The following is a description of a gene set: Human Gene Set: chr14q12 species: Homo sapiens, and this is the list of marker genes: REC8, SCFD1 (sec1 family domain containing 1), NFATC4, LINC02282 (long intergenic non-protein coding RNA 2282), RIPK3, HMGN2P6, TM9SF1 (NCBI Gene Id 10548), LINC02300, NRL, COCH, ZFAND2AP2, FOXG1, RN7SL660P, RNU11-5P, PSME2, RNF31, ADCY4, RPL21P5, TINF2, MIR4307HG, MIR4307, IPO4, CHMP4A, ARHGAP5-AS1, DCAF11, GZMB, CYB5AP5, AKAP6, NOVA1-DT, LINC02306, ARHGAP5, LTB4R2, LINC02294, CBLN3, RNU6-541P, GZMH, FOXG1-AS1, AP4S1, LINC02286, LINC02326, LINC00645, UBE2CP1, NOP9 (NOP9 nucleolar protein), LINC01551, SYF2P1, RPL26P3, G2E3-AS1, RABGGTA, BNIP3P1, LINC02313, BTF3P2, KHNYN, MIR7703, RNU6-864P (NCBI Gene Id 106481776), OR7K1P, KIAA1143P1, LTB4R, ENSG00000309558, MDP1, RNA5SP383, RPL12P5, NUBPL, NEDD8, IRF9, MTCO1P2, PRKD1, NEDD8-MDP1, STXBP6, TSSK4, PSME1, RNU6-1234P, HIGD1AP17, CTSG, LINC02327, RNU6-602P, HEATR5A, ENSG00000258657, EIF4A1P12, RNU6-455P, FITM1, HECTD1 (HECT domain E3 ubiquitin protein ligase 1), DTD2, STRN3, RNU6-8, ENSG00000258525, MIR3171, NUBPL-DT, TGM1, HEATR5A-DT, DHRS1, LINC02293, LINC02281, ENSG00000212270, NYNRIN (NCBI Gene Id 80151), NOVA1, GPR33, MIR3171HG, RNU6-7, GMPR2, CIDEB, CMA1, EMC9, MIR624, G2E3, SDR39U1, ATP5MC1P2